Given this list of marker genes Nfat5, Cog5, Zfp324, Slc30a7, Bnip3, Srrm4, Ikzf4, Fev, Jchain, Mrpl42, Stam, Erich3, Ahcyl1, Rbpj, Ago3, Sdf4, Gm15881, Utrn, Pja2, Tle1, Arfip2, Lrrc41, Pou3f1, Creb3l2, Angel1, Rabep1 (NCBI Gene Id 54189), Inpp5k, Kdm6a, Uimc1, Mga, Sphkap, Sstr3, Arid2 (AT-rich interaction domain 2), Krtap10-4, Rab7, Hdhd2, Phf8, Col10a1, Strn, Trappc2l, Dok5, Snap29, Zfp609, Nnt, Lgals1, Kcnb2, Nudt15, Sp6 (NCBI Gene Id 83395), Ninj2, F13a1, Amot, Gtf2i, Rps6ka6, Ncam1, Dcx, Gabarap, Mgst2, Rhot1, Caly, Mbtd1, Nfatc4, Krt86, Prss43 (serine protease 43), Irag1, Ap1ar, Fbxl19, Snx27, Efna5, Gabrb3, Ro60, Pou2af3, Cd109, Caprin1, Lrrc28, Alg11, Fmo3, Sp1, Cnot6l, Adal, Ireb2, Tshz3, Tor1aip2, Dnaja2, Vdr, Mafg, Sycn, Kcnj16, Bean1, Selenoi, Epb41l3, Hs1bp3, Syne1, Pak5, Ptgr3, Appl1, Cnep1r1, Mest, Dcaf1, Pln, Pafah1b1, Nxpe5, Brd8dc, Klf17, Ppme1, Sdc4 (syndecan 4), Ppp2r2a, Efr3b, Kif5a, Cbx8, AU018091, Socs7, Sh3glb1, Ppp1r9b (NCBI Gene Id 217124), Pate3, Plxna2, Pdc, Dcaf7, Ints15, Aco1 (NCBI Gene Id 11428), Ccdc141, Mid1ip1, Ppp1r1c, Eif4e3, Camsap2, here is a description of the gene set: species: Mus musculus Genes predicted to be targets of miRBase v22 microRNA mmu_miR_7681_3p in miRDB v6.0 with MirTarget v4 prediction scores > 80 (high confidence targets). Mouse Gene Set: MIR_7681_3P from publication Chen Y, Wang X (PMID 31504780)